The following is a description of a gene set: Human Gene Set: KEGG_MEDICUS_VARIANT_MUTATION_CAUSED_ABERRANT_SPTBN2_TO_MGLUR1_TRPC3_SIGNALING_PATHWAY Pathway Definition from KEGG: SPTBN2* -| GRM1 -> GNAQ -> PLCB -> IP3 -> ITPR -> Ca2+ Mutation-caused aberrant SPTBN2 to mGluR1-TRPC3 signaling pathway. Pathway ID: N00960. Pathway type: Variant. Pathway class: nt06462 Spinocerebellar ataxia. studied in species Homo sapiens, and this is the list of marker genes: ITPR1, PLCB4, PLCB3, ITPR3, ITPR2, PLCB1, GRM1, SPTBN2, PLCB2, GNAQ